Given this list of marker genes 9630050E16Rik, Gm8229, Gm32857, Gm21162, Rnase10, Gm3216, Ang4, Gm8256, Gm41138, Gm8518, Ang-ps1, Ptger2, Gm16976, Gm8194, Rpl19-ps3, Apex1, Samd4, Ear-ps8 (NCBI Gene Id 497109), Rnase11, Ear-ps4, Wdhd1, Otx2, Gm3370, Cnih1, Gm10375, Ear-ps10, Gm5206, Ktn1, Gm6498, Pip4p1, Ear-ps1, Or4k15c, 4933429O19Rik, Gm18962, Gm18524, Gm15222, 4930538L07Rik, Atg14, Gm38316, Bmp4, Gm35166, Gm6541, Gm17174, 4930527F14Rik, Ubb-ps, Gm8161, Gm10371, Gm48909, Gm534, Fermt2 (NCBI Gene Id 218952), Ear-ps3, Gm21010, 4930597G03Rik, Gm21154, Or11h6, Gm8417, Gm3287, Gm19109, Gm34060, Or11g7, Ear1, Gm4181, Gm18216, Ang2, Gnpnat1, 4933425B07Rik, Gm35360, Rnase13, Or11g1, Gm46475, Gm5800, Gm7107, Gm19157, Rnase2b, Olfr737-ps1, Ear-ps5, Gm8180 (NCBI Gene Id 676328), Gm17078, 1810028F09Rik, Gm34934, 4930503E14Rik, Rnase4, Or11g2, Gm46453, BC061237, Otx2os1 (orthodenticle homeobox 2 opposite strand 1), Ear6, Gm8247, Gm8046, Gm49306, Gm26782, 4930431P03Rik, Gm24378, Or4m1, Rpph1, Gm7324, 4930572G02Rik, Gm23470, Or4n4b, Gm49261, Gm49083, Or4k1, Cgrrf1, Gm9672, Gm5622, Eddm3b, Gm6526, Ear-ps9, Tmem260, Gm8224, Rnase12, 4930447J18Rik, Gm19156, Gm8353, Or4k15b, Psmc6, Or4k2, Ang, Or11g25, Or11h7, Ear2, Gm34250, Ttc5, Gm7106, Naa30, Armh4, Ccdc198, 2810457G06Rik, Gm17184, Gm17093, Socs4, Ang5, Gm36146, Gm17175, Rnase9, Gm8317, Gm49103, Gm8267, Tep1, Tlr11, Ndrg2, Gm34756, Gm16506, Gm8257, Ear10, Vmn2r-ps110, Gm19158, Gm5930, Ptgdr, Gm6055, Mir378c, Gm16082, Gm6047, Or4k6, Gm9550, Gm3221, Dlgap5, Or4n4, Gm34198, Gm8165, Gm6580, Gm3327, Or11h4b, Gm5799, Styx, Ddhd1, Gm7247, Gm6616, Or4l1, Rnase1, Mapk1ip1l, Gm21754, Or4n5, Gm8232, Slc39a2, Vmn2r-ps111, Ang6, Or11g24, Or11g26, Gm18761, Gm15217, Rubie, Klhl33, Gm7206, Vmn2r88, Gm8220, 1700047E10Rik, Or4q3, AY358078, Exoc5, Parp2, Gm8113, Gmfb, Gm18811, Mir5131, Gm17079, Gm22116, Gm3534, 9530086P17Rik, Or4k5, Gm9502, Gm9587, Or11j4, Or4l15, Txndc16, Gch1, Or6s1, D330046F09Rik, Peli2, Tppp2, Or4k15 (NCBI Gene Id 258316), Ccnb1ip1, Gm10916, Cdkn3, 1700128I11Rik, Gm3371, Ear14, Lgals3, Gm16545, Gm8212, Ear-ps2, Gm8207, Gm15220 (predicted gene 15220), Gm9593, Fbxo34, Mir327, Gm22699, Vmn2r89, Gm35766, Gm15765, Gm10101, Gpr137c, Pnp2, Ear-ps7, Rnase2a, Ang-ps2, Gm41148, Ap5m1, Slc35f4, Pnp, Mettl17, Ang-ps3, Gm18762, Or11g27, Gm16439, Gm6532, Or11h4, A530076I17Rik, Rnase6, Osgep, Ear-ps12, Or11h23, Gm17070, Ero1a (endoplasmic reticulum oxidoreductase 1 alpha), Gm17654, here is a description of the gene set: studied in species Mus musculus Mouse Gene Set: chr14C1